Given this list of marker genes PDGFB, CYBA, MIR17, HMOX1, PDGFRB, IL1B, IL1R1, NOS3, here is a description of the gene set: studied in species Homo sapiens Human Gene Set: GOBP_SMOOTH_MUSCLE_ADAPTATION Any process in which smooth muscle adapts, with consequent modifications to structural and/or functional phenotypes, in response to a stimulus. Stimuli include contractile activity, loading conditions, substrate supply, and environmental factors. These adaptive events occur in both muscle fibers and associated structures (motoneurons and capillaries), and they involve alterations in regulatory mechanisms, contractile properties and metabolic capacities.